Given this list of marker genes VIM, MYH3, TTN, TMOD3, TCAP, TMOD2 (tropomodulin 2), TNNI1 (NCBI Gene Id 7135), TNNT1, TNNT2, ACTN2, DMD, MYL3, TPM4, DES, ACTN3, MYL1, NEB, TMOD1, TNNC1, TNNI3, TPM1, MYBPC1, TNNC2, TPM2 (tropomyosin 2), TMOD4, TNNI2 (NCBI Gene Id 7136), MYH8, MYL4, MYBPC3, MYL2, MYH6, ACTC1 (actin alpha cardiac muscle 1), TPM3, MYBPC2 (NCBI Gene Id 9115), ACTA1, TNNT3, here is a description of the gene set: Human Gene Set: REACTOME_STRIATED_MUSCLE_CONTRACTION species: Homo sapiens Striated Muscle Contraction